The following is a description of a gene set: Human Gene Set: MIR4667_3P from publication Chen Y, Wang X (PMID 31504780) Genes predicted to be targets of miRBase v22 microRNA hsa-miR-4667-3p in miRDB v6.0 with MirTarget v4 prediction scores > 80 (high confidence targets). studied in species Homo sapiens, and this is the list of marker genes: FAM110A, LMNB1 (lamin B1), MAGI1, HIC2, GPR61, COL12A1, DAPK1 (death associated protein kinase 1), SNX18, AGO1, SLC2A3, OLIG3, SLC2A14, C2CD2L, GNL1, FAM168A, ITGA10, PARD3B (par-3 family cell polarity regulator beta), AP3M2, RAD54L2, GSG1L, DLG4, NSD1, PRTFDC1, NFASC, UCK2, CNNM2, ELN (NCBI Gene Id 2006), GRAMD1B, NKD1, ARHGAP17, NEURL1B (neuralized E3 ubiquitin protein ligase 1B), ASTN1, KPNB1, RPS6KA3, MAP2K1, ESF1, ST3GAL1, NAT8L (NCBI Gene Id 339984), ANKRD52, KCNQ2, SYNGAP1, NAV1, PCDH1, MECP2, C3orf38, SNPH, DMRT2, STK35, CFAP68, NRG3, GPR55, CCDC184, LSAMP, OXSR1, SMIM12 (NCBI Gene Id 113444), AOPEP, HAS3, PABPN1, RNF138, EBF3, BTK, NECAP2, SNX8 (NCBI Gene Id 29886), TNKS, NCDN, SF3B1, ZNF728, IRGQ, TMEM105, MIEF2, ZNF212, RAB11FIP3, MAP3K13, CXXC4, NCAM1, EMP1, CCDC9B, FKBP5, UBE2K, KALRN, HIPK2, RAB5B, MEX3A, FLVCR2, CLDN1, HIF1AN, PLLP, HMGXB3, TUBB6, ALPK3, CBX1, DPPA2, MYORG, TLE4 (TLE family member 4, transcriptional corepressor), KCNS1, RASSF3, TMEM50A, GRAP2, ELFN2, RBL2, BRD2, HNF1A, MED1, ADGRL1, ENAH, CACNG8, MGAT5, NEUROG2, ZNF234, PLCXD3, TARS3, BAHD1, DESI2, USP5, TSC1, SERPINA5, TBCEL, NRBP1, ATP8B2, RNF222, SRF, TRIT1, FRA10AC1, BCL2L2-PABPN1, SCMH1, HMGN2, SHISA6, C2CD5, BAG4, TOMM40